Given this list of marker genes Msh3, Msh2, Rmi2, Tcf7l2, Zmpste24, Axin2, here is a description of the gene set: Any process involved in sustaining the fidelity and copy number of DNA repeat elements. studied in species Mus musculus Mouse Gene Set: GOBP_MAINTENANCE_OF_DNA_REPEAT_ELEMENTS